The following is a description of a gene set: from publication Liberzon A, Birger C, Thorvaldsdóttir H, Ghandi M, Mesirov JP, Tamayo P (PMID 26771021) Human Gene Set: HALLMARK_UNFOLDED_PROTEIN_RESPONSE studied in species Homo sapiens Genes up-regulated during unfolded protein response, a cellular stress response related to the endoplasmic reticulum., and this is the list of marker genes: KHSRP, EXOSC2, H2AX, WIPI1, EIF4G1, PDIA6, DDIT4, HSPA5, PREB, ATP6V0D1, EIF4A3, YWHAZ, SERP1, SRPRB, SHC1, EXOSC10, EDC4, CNOT6, TATDN2, LSM1, NOLC1 (nucleolar and coiled-body phosphoprotein 1), EIF4A1, DCP2, ATF3, DCTN1, SPCS3, EXOSC4, NOP14, SSR1, EIF2S1 (NCBI Gene Id 1965), NFYB, HSPA9, MTHFD2, DNAJA4, SDAD1, TSPYL2, HERPUD1, WFS1, SRPRA, ZBTB17, CHAC1, YIF1A, EIF2AK3, NFYA, DDX10, ERN1 (NCBI Gene Id 63433), EXOSC1, CEBPG, SLC30A5, SLC7A5, STC2, TARS1, IGFBP1, ATF6, PARN, EXOC2, GOSR2, EDEM1, KIF5B, PAIP1, TUBB2A, CNOT4, EIF4E, ARFGAP1, NPM1, NHP2, POP4 (POP4 homolog, ribonuclease P/MRP subunit), RPS14, RRP9, EXOSC9, XPOT (NCBI Gene Id 11260), DNAJB9 (DnaJ heat shock protein family (Hsp40) member B9), NOP56, SLC1A4 (solute carrier family 1 member 4), CNOT2, EIF4A2, EEF2, IFIT1, HSP90B1, DCP1A, EIF4EBP1, HYOU1, SEC31A, DKC1, MTREX, SKIC3, ASNS, ALDH18A1, SPCS1, BAG3, FUS, DNAJC3 (NCBI Gene Id 5611), PDIA5, PSAT1, LSM4, KDELR3, CCL2, NABP1, SEC11A, BANF1, ERO1A, IMP3, CEBPB, CKS1B, VEGFA, GEMIN4, FKBP14, XBP1, IARS1, EXOSC5, CXXC1, CALR, ATF4